Given this list of marker genes SCUBE3, SLC26A2 (NCBI Gene Id 1836), GMNN, SOX9, EHMT1, RAC1, POLR1A (NCBI Gene Id 90784), IDS, here is a description of the gene set: Human Gene Set: HP_TRACHEOBRONCHOMALACIA studied in species Homo sapiens Weakness of the cartilage in the trachea and the bronchi, resulting in a floppy (non-rigid) airway. Affected persons may have difficulties to maintain patency of the airways. Tracheobronchomalacia